The following is a description of a gene set: Human Gene Set: SMITH_TERT_TARGETS_DN species: Homo sapiens Most somatic cells do not express sufficient amounts of telomerase to maintain a constant telomere length during cycles of chromosome replication. Consequently, there is a limit to the number of doublings somatic cells can undergo before telomere shortening triggers an irreversible state of cellular senescence. Ectopic expression of telomerase overcomes this limitation, and in conjunction with specific oncogenes can transform cells to a tumorigenic phenotype. However, recent studies have questioned whether the stabilization of chromosome ends entirely explains the ability of telomerase to promote tumorigenesis and have resulted in the hypothesis that telomerase has a second function that also supports cell division. Here we show that ectopic expression of telomerase in human mammary epithelial cells (HMECs) results in a diminished requirement for exogenous mitogens and that this correlates with telomerase-dependent induction of genes that promote cell growth. Furthermore, we show that inhibiting expression of one of these genes, the epidermal growth factor receptor (EGFR), reverses the enhanced proliferation caused by telomerase. We conclude that telomerase may affect proliferation of epithelial cells not only by stabilizing telomeres, but also by affecting the expression of growth-promoting genes. Genes consistently down-regulated in HMEC cells (primary mammary epithelium) upon expression of TERT off a retroviral vector. from publication Smith LL, Coller HA, Roberts JM (PMID 12717449), and this is the list of marker genes: LIPA, VSNL1, SIRPA, SPEG, SRD5A1, A2M, CHMP1A, APEX1, FAH, FAM53B, STAT4, TUBB3 (NCBI Gene Id 94749, tubulin beta 3 class III), UNC119, TAGLN, GRK5, THY1, NEFL, CAT, POU5F1, PAM, ALDH3A2, IL1RN, DHCR24, RAB11A, ALDH7A1, SERPINB6, PIK3R3, RAB40B, NME4, PML, CCNG1, DNA2, PTHLH, NSDHL, FOSB, AHCY, GAMT, PGF, CPOX, DUSP6, PPP1R7, VAV2, SORD, LAMP2, AKR1C3, UGP2, HSPA2, CD47, GSN, TNFSF10, PCNA, ARHGAP25, SAA1, USP47, ANXA4, GSTO1, NID2, TNFSF9, SP110, GM2A, IDI1, AKT1, PNP (purine nucleoside phosphorylase), PON2, KANK1, ARHGDIB, RRAGA, CBR1, ASAH1, EHHADH, KYNU, SERPING1, TCF4, CDSN, CLP1, ABR, CALML3, XRCC5, NEFM (neurofilament medium chain), MMP2, L1CAM, TRADD, TST, IFI30 (IFI30 lysosomal thiol reductase), ACLY, OAT, ADIPOQ